Given this list of marker genes NDUFB9, RIN2, THOC7, TMEM141, ADM, ATP5PF, DMRTA2, SCARB2, SMIM5, SLCO3A1, SPINT1, FOSB, SQLE, CLDN1, ATP5F1E, MIEN1, PLEKHN1, PLXDC2, HMGCS1, BBOX1, TXN, VTI1B, HRK, POLR2I, TAGLN2, REEP4, CRB3, OSBPL1A, BNIPL, SMAD3 (NCBI Gene Id 51521), FAM210B, NFATC3, EVPL, ANXA11, DAZAP2, MTUS2, HMGN1, UBL5, MT1E, S100A6, TFRC (transferrin receptor), FRMD4A, ERBB3, ARHGEF3, HSBP1L1, RAPGEFL1, PID1, COX7B, SRCAP, EGR1, MOCS2, PNKD, TNS4, FAM169A, JUN, MICOS10, NDUFB2, RRAD, PDCD4, EPHA2, SH3GL3, ELP4, NDUFB7, KAT2B, EMP2, NMRK1, PAIP2, IER5, ATP5PD, RAP2B, TMEM19, MIF, LSM4, ATP5MF, SRD5A1, NDUFA4, RBX1, PTPN13, GALNT3, CRIP1, MKRN1, MT1M, THBD, ARHGEF4, RAB40B, SREBF1, SOX15, EZR, METTL17, FSIP1, SRP9, NR4A1, PEBP1, ESRP1, CHMP2A, RHOU, POF1B, MYO6, IDI1, COMT, MYCBP2, PLP2, GJB5, KCTD1, CDKN2B, CLU, SELENOK, COX14, UQCRQ, VAV3, CCDC12, ATP5MK, ATP5MJ, PFN2, KLF10, PSAP, LIPH, TOM1L1, SMIM30, HS3ST6, CPAMD8, SAT1, BHLHE41, ZFYVE21, PSAT1, ARPC2, COA3, CDKN1C, HES4, COX17, DSP-AS1, CDC42, DNAJB2, PPL, WNK2, NDUFB3, NQO1, EFCAB14, PRDX1, YWHAZ, OXR1, COX6A1, BAG1, EMP1, MBD2, COX6C, CLCA2 (NCBI Gene Id 9635), MACROH2A1, ANXA2, CLEC7A (C-type lectin domain containing 7A), XDH, GLTP, here is a description of the gene set: studied in species Homo sapiens Occular cell types curated from Gautam and Hamashima et al. Multi-species single-cell transcriptomic analysis of ocular compartment regulons from publication Gautam P, Hamashima K, Chen Y, Zeng Y, Makovoz B, Parikh BH, Lee HY, Lau KA, Su X, Wong RCB, Chan WK, Li H, Blenkinsop TA, Loh YH (PMID 34584087) Human Gene Set: GAUTAM_EYE_CORNEA_ELF3_HIGH_EPITHELIAL_CELLS